Given this list of marker genes WT1, BAIAP3, MLF1 (NCBI Gene Id 4291), IL2RB, TSPAN7, PDGFA, here is a description of the gene set: species: Homo sapiens Human Gene Set: KEGG_MEDICUS_VARIANT_EWSR1_WT1_FUSION_TO_TRANSCRIPTIONAL_ACTIVATION Pathway Definition from KEGG: EWSR1-WT1 => (PDGFA,IL2RB,BAIAP3,TSPAN7,MLF1) EWSR1-WT1 fusion to transcriptional activation. Pathway ID: N00137. Pathway type: Variant. Pathway class: nt06240 Transcription.